Given this list of marker genes PARP14, SIRT3, SIRT2, PARP9, TNKS, SIRT5, PARP16, ART5, PARP10, PARP15, ART3, ART4, PARP11, TNKS2, SIRT1 (sirtuin 1), SIRT6, PARP2, PARP12, SIRT4, PARP1, PARP6, ART1, ZC3HAV1, PARP4, TIPARP, PARP3, PARP8, ARF4, here is a description of the gene set: species: Homo sapiens Catalysis of the reaction: amino acyl- + NAD+ = H+ + (ADP-D-ribosyl)-amino acyl- + nicotinamide. Human Gene Set: GOMF_NADPLUS_PROTEIN_MONO_ADP_RIBOSYLTRANSFERASE_ACTIVITY